Given this list of marker genes TMEM30B, TRIAP1, P2RX7, ATP8A2, TMEM63B, ATG9A (NCBI Gene Id 79065), ATP10D, XKR9, PLSCR5, ANO6, ANO7, ABCB1, PRELID1, ABCA12, KCNN4, ARV1 (ARV1 homolog, fatty acid homeostasis modulator), PLSCR4, ATP10A (NCBI Gene Id 57194), TLCD2, VDAC2, ATP11B, SLC4A1, ATP8B3, ATP9A, ABCC1, ABCA2, ABCA3, ABCA1, ATP11A, ATG9B, FASLG, XKR8, ATP10B, GBA2, SERINC5, MFSD2A, ABCA4, ANO4, ATP8B2, XRCC4, XKR7, XKR4, XKR6 (XK related 6), ABCB4, ANO3, ATP11C, ATP8A1, PLSCR2, TMEM30A, ABCG1, PLSCR1, ANO9, RFT1, SLC66A2, TRPC5, SERINC2, SERINC3, TMEM41B, ATP9B, TLCD1, PLSCR3, ABCA7, CLPTM1L, VMP1, ATP8B1, ATP8B4, here is a description of the gene set: Any process that modulates the proportions or spatial arrangement of lipids in a cellular membrane. Human Gene Set: GOBP_REGULATION_OF_MEMBRANE_LIPID_DISTRIBUTION species: Homo sapiens